The following is a description of a gene set: Human Gene Set: GOBP_MAST_CELL_ACTIVATION_INVOLVED_IN_IMMUNE_RESPONSE species: Homo sapiens The change in morphology and behavior of a mast cell resulting from exposure to a cytokine, chemokine, soluble factor, or to (at least in mammals) an antigen which the mast cell has specifically bound via IgE bound to Fc-epsilonRI receptors, leading to the initiation or perpetuation of an immune response., and this is the list of marker genes: LYN, RABGEF1, CD300A, ENPP3, FCER1G, FERRY3 (NCBI Gene Id 57200), ADGRE2, CPLX2, GAB2, CD84, PTGDR, VAMP2, KIT, CBL, VAMP7, RAC2, LGALS9, PIK3CG, SNX6, IL4R, GPR15LG, GATA1, CLNK, STXBP1, GATA2, SYK, SNX4, PLA2G3, NR4A3, BTK, IGHE, SPHK2, IL13RA2, ADORA2B, STXBP2, LAT, FGR, VAMP3, MRGPRX2, PTGDS, FER, FOXF1, SNAP23, MILR1, GRP (NCBI Gene Id 2922), PDPK1, SCN11A, CHGA, LAT2, FCER1A, RASGRP1, PIK3CD, IL13, PTPN6, SLC18A2, UNC13D, S100A13, RAB44, FES, VAMP8